Given this list of marker genes ARHGEF2, RAB10, TEAD3, FGF13, SOX5, DOCK7, here is a description of the gene set: species: Homo sapiens Human Gene Set: GOBP_ASYMMETRIC_NEUROBLAST_DIVISION The process resulting in the physical partitioning and separation of a neuroblast into two daughter cells with different developmental potentials.